The following is a description of a gene set: studied in species Homo sapiens Genes up-regulated in bone marrow-derived mast cells treated with IL3: control versus IL33. Human Gene Set: GSE39382_IL3_VS_IL3_IL33_TREATED_MAST_CELL_UP Interleukin-33 (IL-33) is elevated in afflicted tissues of patients with mast cell-dependent chronic allergic diseases. Based on its acute effects on mouse mast cells (MCs), IL-33 is thought to play a role in the pathogenesis of allergic disease through MC activation. However, the manifestations of chronic IL-33 exposure on human MC function, which best reflect the conditions associated with chronic allergic disease, are unknown. We now find that long-term exposure of human and mouse MCs to IL-33 results in a substantial reduction of MC activation in response to antigen. This reduction required >72 h exposure to IL-33 for onset and 1-2 wk for reversion following IL-33 removal. This hypo-responsive phenotype was determined to be a consequence of MyD88-dependent attenuation of signaling processes necessary for MC activation including antigen-mediated calcium mobilization and cytoskeletal reorganization; potentially as a consequence of down-regulation of the expression of PLCg1 and Hck. These findings suggest that IL-33 may play a protective, rather than a causative role in MC activation under chronic conditions and, furthermore, reveal regulated plasticity in the MC activation phenotype. The ability to down-regulate MC activation in this manner may provide alternative approaches for treatment of MC-driven disease. from publication Jung MY, Smrž D, Desai A, Bandara G, Ito T, Iwaki S, Kang JH, Andrade MV, Hilderbrand SC, Brown JM, Beaven MA, Metcalfe DD, Gilfillan AM (PMID 23248261), and this is the list of marker genes: ENOSF1, GATM, CD37, ZNF395, KLHL7, CAB39, PCSK5, RAD51AP1, NACA, ABHD10, POLR2L, PDXK, ITGAE, CAT, TULP4, AP2S1, HLA-DQB1, PIK3R1, IKZF1, PIK3CD, SPINT2, NTAN1, TBC1D5, FKBP1A, UNC119, BST1, ITPK1, RAMP1, KLHDC3, LRRFIP1, IFNGR1, FRAT2, OGT, AKR1A1, FKBP15, MRM2, PCBP2, RPP30 (ribonuclease P/MRP subunit p30), MKNK1, PPP3CA, CD9, KLF7, CLTC, CD74, SNRNP200, CITED2, NUP43, HGSNAT, RASGRP3, ALDH9A1, GDE1, UQCR11, MS4A4A, RTN3, TRIM23, TACC3, APH1B, ME1, GUSB, HELZ, SLC7A8, TET3, OTULINL, UQCRQ, NCKAP1L, TACC1, CERS2, EPB41L2, VAMP4, TXNIP, IRAK1, HIGD2A, GNPDA1, PBX3, STAU2, SRGAP3, DDOST, GSN, ABHD6, LMBRD1, LRP5L, UBAP2L, MAT2A, STAM, ADA2, POR, NDUFA4, GIGYF2, PIGP, HS2ST1, COQ9, SLC2A8, CARS2, MXI1, FIS1, BRWD1, ALDH4A1, GID8, SURF1, DYRK4, SLC66A2, CORO1B, PRKD3, RMND5A, RASSF1, SLC25A6 (NCBI Gene Id 8283), SIGIRR, IFFO1, CHCHD7, DENND1C, SELENOT, NFATC1, HEATR3 (NCBI Gene Id 55027), HTT, MCM2, LZTFL1, QKI (QKI, KH domain containing RNA binding), SMYD2 (NCBI Gene Id 56950), TDP1, HPS1, SCLY, PCK2, TM9SF1, CTDSP1, SELPLG, NCOR2, CACYBP, ABL1, HSPBAP1, SNHG32, VEGFB, ZMIZ1, MGAT1, CREBL2, UROD, GSE1, ELOB, APEH (NCBI Gene Id 95915), DPEP2, SYK, DBP, CBR4, ANKRD6, MGST3, RNFT1, ARHGAP17, VAV1, SCARB1, SH3GL1, NENF, EFCAB11, GASK1B, MICAL1, NDUFB8, WDR26, FOCAD, ALDH6A1, PLAU, STAB1, DGLUCY, PARL, CDC40, MGST2, STARD13, PFDN5, FAM8A1, OLR1, KIAA0232, HDAC5 (histone deacetylase 5), CBX7, SLC5A3, PRKAR2A, PILRA, BLTP2, QDPR, HACD1, MTO1, HMGB2, RPS6KA2, HLA-DPB1, PIP5K1C, SLC2A9, BTBD2, MARF1, RPS23, RPL35A, ADAM10, OSBPL11, REPS2, ANKFY1, RPP14 (NCBI Gene Id 115127), TNFRSF14 (NCBI Gene Id 93208), INTS8, ATP5MG, ARHGAP4, PPP1CC, SIAH1, LY86, PCMTD2, HSP90B1